The following is a description of a gene set: The heterotrimeric G protein G alpha (z), is a member of the G (i) family. Unlike other G alpha (i) family members it lacks an ADP ribosylation site cysteine four residues from the carboxyl terminus and is thus pertussis toxin-insensitive. It inhibits adenylyl cyclase types I, V and VI (Wong Y H et al. 1992). G alpha (z) interacts with the Rap1 GTPase activating protein (Rap1GAP) to attenuate Rap1 signaling. Like all G-proteins G alpha (z) has an intrinsic GTPase activity, but this activity tends to be lower for the pertussis toxin insensitive G-proteins, most strikingly so for G alpha (z), whose kcat value for GTP hydrolysis is 200-fold lower than those of G alpha (s) or G alpha (i). G alpha (z) knockout mice have disrupted platelet aggregation at physiological concentrations of epinephrine and responses to several neuroactive drugs are altered. Regulator of G-protein Signalling (RGS) proteins can regulate the activity of G alpha (z) (Soundararajan M et al. 2008). Reactome Pathway: G alpha (z) signalling events part of: GPCR downstream signalling studied in species Homo sapiens, and this is the list of marker genes: ADCY5, GNB4, GNAZ, GNB1, PRKCG, RGSL1, GNAS, GNGT2, ADCY3, GNB2, GNAT3, GNG11, GNG2, GNG12, GNB3, ADCY2, ADCY6, ADCY4, GNAI3, PRKCD, GNG13, GNG4, ADCY1, ADRA2A, GNAI2, ADCY7, RGS16, GNG5, PRKCQ, GNG8, PRKCH, RGS20, ADCY8, PRKCA, PRKCB, GNB5, GNG7, RGS4, RGS17, GNAI1, GNG10, ADCY9, GNGT1, GNG3, ADRA2B, RGS19, PRKCE, ADRA2C